The following is a description of a gene set: Glutathione conjugation studied in species Mus musculus Mouse Gene Set: REACTOME_GLUTATHIONE_CONJUGATION, and this is the list of marker genes: Gsto2, Chac2, Cndp2, Gclc, Gsta1, Gstt2, Ggct, Oplah, Gstm6, Gstm1, Esd, Gsto1, Gss, Gsta13, Hpgds, Ggt6, Gsta2, Ggt7, Chac1, Gstm2, Gstz1, Gstp2, Mgst1, Mgst3, Gsta3, Ggt5, Gstk1, Mgst2, Gclm, Gstm7 (glutathione S-transferase, mu 7), Akr1a1, Gstt1, Gstm4, Ggt1, Gstp1, Gstm3, Gsta5, Gstm5